The following is a description of a gene set: part of: Signaling by Receptor Tyrosine Kinases studied in species Homo sapiens Reactome Pathway: Signaling by ALK The anaplastic lymphoma kinase (ALK) is a transmembrane receptor tyrosine kinase that, along with related receptor LTK (leukocyte tyrosine kinase receptor) is a member of the insulin receptor superfamily. ALK was discovered as an oncogene in anaplastic large cell lymphomas (ALCLs), but also plays an oncogenic role in other cancer types, such as non-small-cell lung cancer (NSCLC), inflammatory myofibroblastic tumours (IMT), melanoma, neuroblastoma and glioblastoma. In cancer, the chromosomal region encoding ALK frequently undergoes genomic rearrangements, resulting in the formation of ALK fusion proteins, such as NPM‑ALK (the result of a translocation event, t(2;5)(p23;q35) which is predominant in ALCL) and EML4‑ALK (an inversion event on chromosome 2). These fusion proteins consist of the C‑terminal region of ALK, encompassing the kinase domain and the effector protein binding domain (with loss of the transmembrane domain), while the N‑terminus of the fusion protein contains the dimerization domain of the partner gene. Fusion proteins of ALK are therefore capable of ligand‑independent dimerization, resulting in constitutive ALK signaling. Additionally, amplification of ALK and/or point mutations leading to its constitutive activation have been detected in neuroblastoma. <br><br>Many of the functional studies on ALK have been conducted in the context of oncogenic forms of the protein. In contrast, fewer studies have been conducted on the wild type protein under normal physiological conditions, and indeed, ALK was initially classed as an orphan receptor with no identified ligand. Two small heparin-binding growth factors, pleiotrophin (PTN) and midkine (MDK), were initially identified as potential ligands however subsequent studies failed to support this. More recently, ALKAL1 and ALKAL2 (also known as FAM150A and FAM150B) have been identified as ligands for both ALK and the related LTK receptor, albeit with differing potencies. Whereas LTK receptor is potently activated by both ALKAL1 and ALKAL2, ALK is only weakly stimulated by ALKAL1. Ligand binding induces the dimerization of the receptor and transautophosphorylation, resulting in a fully activated receptor that triggers downstream signaling cascades such as RAS, PI3K and IRS1 signaling. ALK may also undergo ligand-independent activation through RPTPB/RPTPZ. <br><br>ALK is mainly expressed in the developing central and peripheral nervous system and plays a role in differentiation during development. In Drosophila and mice, ALK is a thinness gene involved in the resistance to weight gain. Through activation of STAT3 targets, ALK also appears to play a role in response to ethanol., and this is the list of marker genes: PTN, JAK3, SRC, PIK3R1, PIK3CA, HDAC2, DNMT1 (DNA methyltransferase 1), PIK3R2, HIF1A, PIK3CB, PTPRZ1, EP300, PRDM1, SIN3A, ALKAL1, PTPN6, MDK, FRS2, ALKAL2, PLCG1, IRS1, ALK, IL2RG, HDAC1, MYC, CD274, STAT3, SHC1, MYCN, HDAC3